The following is a description of a gene set: species: Homo sapiens from publication Piccaluga PP, Agostinelli C, Califano A, Carbone A, Fantoni L, Ferrari S, Gazzola A, Gloghini A, Righi S, Rossi M, Tagliafico E, Zinzani PL, Zupo S, Baccarani M, Pileri SA (PMID 18006812) Human Gene Set: PICCALUGA_ANGIOIMMUNOBLASTIC_LYMPHOMA_DN Down-regulated genes in angioimmunoblastic lymphoma (AILT) compared to normal T lymphocytes. Angioimmunoblastic lymphoma (AILT) is the second most common subtype of peripheral T-cell lymphoma (PTCL) and is characterized by dismal prognosis. Thus far, only a few studies have dealt with its molecular pathogenesis. We performed gene expression profile (GEP) analysis of six AILT, six anaplastic large cell lymphomas (ALCL), 28 PTCL-unspecified (PTCL/U), and 20 samples of normal T lymphocytes (including CD4(+), CD8(+), and activated and resting subpopulations), aiming to (a) assess the relationship of AILT with other PTCLs, (b) establish the relationship between AILT and normal T-cell subsets, and (c) recognize the cellular programs deregulated in AILT possibly looking for novel potential therapeutic targets. First, we found that AILT and other PTCLs have rather similar GEP, possibly sharing common oncogenic pathways. Second, we found that AILTs are closer to activated CD4(+), rather than to resting or CD8(+) lymphocytes. Furthermore, we found that the molecular signature of follicular T helper cells was significantly overexpressed in AILT, reinforcing the idea that AILT may arise from such cellular counterpart. Finally, we identified several genes deregulated in AILT, including PDGFRA, REL, and VEGF. The expression of several molecules was then studied by immunohistochemistry on tissue microarrays containing 45 independent AILT cases. Notably, we found that the vascular endothelial growth factor (VEGF) was expressed not only by reactive cells, but also by neoplastic cells, and that nuclear factor-kappaB (NF-kappaB) activation is uncommon in AILT, as suggested by frequent exclusively cytoplasmic c-REL localization. Our study provides new relevant information on AILT biology and new candidates for possible therapeutic targets such as PDGFRA (platelet-derived growth factor alpha) and VEGF., and this is the list of marker genes: THAP2, KDM3A, CHASERR, NAMPT, RAPGEF6, PCIF1, CD6, YPEL5, SIK1, TSC22D2, RGS2, IRF2BP2, TSC22D3, MAP3K4-AS1, FBXW7, SRSF5, RNF139, JUND, PPP1R15B, CHD1, MGAT4A, REL, G3BP2 (G3BP stress granule assembly factor 2), MPZL3, FOSB, ATP2B1-AS1, IDS, BTG1, EPC1, SMG1P5, MYLIP (NCBI Gene Id 29116), LY9, H3-3B, IFRD1, SLC2A3, HAUS3, SIK3, JMJD1C (jumonji domain containing 1C), PTP4A2, SUCO, FOSL2, CD69, SON, TP53INP2, PTP4A1, RNF11, CBX4, RNF103, KLF4, PER1, PMAIP1, SBDS (SBDS ribosome maturation factor), FOXP1 (forkhead box P1), IKZF5, TSPYL2, GATA3, TRA2B, KLF10, SETD2, ZFC3H1 (NCBI Gene Id 26055), ZFAND2A, AREG, EIF5, JMY, COG3, MCL1, SARAF, PRNP (prion protein (Kanno blood group)), PPP1R15A, RGS1, TIPARP, DNAJB6, PNPLA8, EIF4G3, AMD1, ZFP36, CREM, DDX3X, CCNL1, MXD1, RSRC2, WIPF1, MEX3C (mex-3 RNA binding family member C), TOB1, RGCC, KDM6B, NDUFA10, STK17B (NCBI Gene Id 9262), ETNK1, H2AC18, KLF6, CSRNP1, PELI1 (pellino E3 ubiquitin protein ligase 1), SMURF2, HIPK1, JUN, SLC30A1, EIF1, ZBTB10, GADD45A, TNFAIP3, B3GNT2, TTC7A, MOAP1, TMX4 (NCBI Gene Id 56255), IER5, IRS2, DUSP10, ING3, FBXO33, ZNF331, TUBB2A, CCDC59, GADD45B, DUSP4, ID2, HECA, CNST, PHF1, ZFAND5, PDE4D, PTGER4 (NCBI Gene Id 5734), CSGALNACT2, MAP3K8, NR4A2, ZBTB24, CLK1, TBC1D22A-DT, DUSP2 (NCBI Gene Id 1844), HAPSTR1, PIGA, NR4A3, CNOT6L, GABARAPL1, SNORD3B-1 (small nucleolar RNA, C/D box 3B-1)